Given this list of marker genes Cd9, Pdpn, Tmx1, Adamts18, Lyn, Ceacam1, Sh2b3, Il6ra (interleukin 6 receptor, alpha), Mmrn1, Ctsg, Alox12, Prkg1, Vps33b, Mfsd2b, Ubash3b, F11r (NCBI Gene Id 226655), Jak2, Htr2a, Prkcd, C1qtnf1, Emilin1, Syk, Cela2a, Serpine2, Prkca, Il6, Emilin2, Prkcq, here is a description of the gene set: species: Mus musculus Mouse Gene Set: GOBP_REGULATION_OF_PLATELET_AGGREGATION Any process that modulates the rate, frequency or extent of platelet aggregation. Platelet aggregation is the adhesion of one platelet to one or more other platelets via adhesion molecules.